The following is a description of a gene set: Mouse Gene Set: TABULA_MURIS_SENIS_MESENTERIC_ADIPOSE_TISSUE_MESENCHYMAL_STEM_CELL_OF_ADIPOSE_AGEING studied in species Mus musculus from publication Tabula Muris Consortium (PMID 32669714), and this is the list of marker genes: Sf3b2, Tppp3, Camk2n1, Gnb1, Tpt1, Elovl1, Ier3, Prr13, Rap1a, Ifngr2, Numbl, Eya2, Nras, H2-K1, Shisa5, Nbl1, Snai1, Laptm4a, Eln, Tmed9, Comt, Tex261, Pcnp, Ckb, Rab11b, Xbp1, Mtarc2, Dnaja1, Bclaf1, Cd151, Brd2, Pdxk, Arid1a, Fubp3, Fosl2, Anxa3, Rps7, Rpl8, Tmsb10, Cited2, Hsp90aa1, Ube2m, Serbp1, Rps20, Snrpb, Vat1, Sdf2l1, Btg1, Vapb, Ctbp2, Ccl11, Igsf3, Cytl1, Ccnl1, Ccnd3, Pdlim1, Mtdh, Elof1, Ints6, Iqgap1, Atn1, Hnrnpr, Rras, Rps9, Ddx39b, Rsrc2, Vapa, H2-D1, Rbpms, Lrp1, Tnfrsf1a, H2-Eb1, Sbds, Mdh1, Vps72 (vacuolar protein sorting 72), Gnas, Bcl3, Rpl13a, Abhd8, Dnajb1, Capg, Ier2, Trip10, Mospd3, Bcl7c, Arglu1, Ptms, Ptges3, Hsp90ab1, Map7d1, Prnp, Sox4, Emd, Zfp503, Ppp4c, Arpc4, Arpc2, Eva1b, Sox9, Fxyd6, Zfp36, Kmt2b, Apbb1ip, Mboat7, Pim3, Pabpc1, Czib, Cavin1, Ap2s1, E2f4, H2-M3, Rpl5, Zfand5, Eif1a, Tbcb, Rhoa, Rpl11, Mknk2, Hdac7, Eif1, Nkx2-3, Rspo1, Ybx3, Ddx6, Nav1, Pdlim4, Ralbp1, Tkt, Phb2, Eif3h, Npc2, Palld, Ebf1, Mtch1, Rpl17, Bmyc, Rnf126, Gm3336, Stxbp6, Hspa4, Spr, Ubxn1, Emc10, C3, Twf1, Abhd17a, Syf2, Eif4g1, Snrnp70, Sf3b4 (splicing factor 3b, subunit 4), Dbn1, Scn1b, Selenom, Marcks, Bin1 (NCBI Gene Id 30948), Thbd, Tomm6, Ppp1r11, Cebpg, Rps25, Zfhx3, Phactr2, Vcf1, Pa2g4, Eif4a1, Pfn1, Gatad1, Grb2 (growth factor receptor bound protein 2), Nfkbib, Dgat1, Eif4e, Tmem9, BC005624, Srsf9, Mea1, Zfpl1, Zfp703, Ddah2, Ftl1, Pla1a, Fkbp2, Clic4, Mgst1, Nucks1 (nuclear casein kinase and cyclin-dependent kinase substrate 1), Ift27, Rps2 (ribosomal protein S2), Bsg, Dock1 (NCBI Gene Id 71571), Csrp1, Tpm3, Ldha, Ifitm2, Hprt1, Eif3k, Rpl18, Palm, Psme1, Tpm2, Srrm2, Tcf7l1, Tmt1a, Eif3m (eukaryotic translation initiation factor 3, subunit M), Pkig, Slc25a3, C1qc, Arpc1b, Stx4a, Gadd45gip1, Trabd2b, Use1 (NCBI Gene Id 76848), Cotl1, Apoe, Aldoa, G3bp1, Fkbp8, Pcbp1 (poly(rC) binding protein 1), Kdelr1, Med1, Dnajc3, Mfap2, Babam1, Vamp2, Szrd1, Ak2, Hmox2, Zyx, Hmbs, Klf7, Hnrnpd, Has1, Igfbp7, Sumo3, Ltbp1, Znhit1, Ptp4a2, Cnp, Il3ra, Ube2e1, Ube2e3, Tmod2, Klf3, Plpp3, Pakap, Ptgis, Gsta3, Vezf1, Ifi211, Rrp1, Rarg, Eri3, Oaz1, Anp32b, Csrnp1, Tubb6, Prdx5, Nabp2, Srsf7, Arc (activity regulated cytoskeletal-associated protein), Tamalin, Cnpy3 (canopy FGF signaling regulator 3), Cxxc5 (NCBI Gene Id 67393), Rps3, Junb, Yme1l1, Rrbp1, Ccdc6, Arl6ip1, Rhoj, Hspa1a, Akt1s1, Rack1, Rock1, Actr2, Atoh8, Otub1, Pea15a, Ifi35, Set, Des, Rpl9, Tmem263, Snrpa, Ube2v1, Ubb-ps, Rhoc, Plin2, Lrrn4cl, Cltb, Hic1, Map2k2, Fgf18, Tsen34, Ino80e, Aig1, Rps5, Psmb8, 1700019D03Rik, Gna11 (NCBI Gene Id 327779), Stx5a, Tob1, Pebp1, Eef1b2, Rpl13, Steap3, Lmo4, Lsm2, Mapk3, Nsg1, Ramp2, Clec3b, Trappc3, Pdpn, Ubl7, Maf, Sdc4, Oaf, Myc, Bst2, Fam120a, Cd9, Fxyd1 (NCBI Gene Id 80524), Cmtm3, Golt1b, Tubb5, Inpp4a, Pnrc1, Spin1, Yif1b, Txn2, Tnfaip2, Cirbp, Gabarapl2, Eif5a, Cald1, Efhd2, Sod1, Mycbp2, Phf1, Fam89b, Mlf2, Trp53, Nudc, Rhob, Hspb1, Tmem160, Tmem250, Brd4, Ngf, Gstm1, Cfl1, H2-Ab1, Mn1, Cdkn1a, Creld2, Nr3c1, Ehd1, Calr, Ssbp3, Mmp11, Dhrs4, Rap2a, Arl2bp, Lmo2, Kdm6b, Ubxn4 (UBX domain protein 4), Ldhb, Nudt3, Plekhj1, Lmna, Ttyh2, Efcab14, Sfrp1, Ubtf, Mafb, Loxl1, Lamtor1, Zbtb7a, Spon2, Cebpb, Canx, Gabarapl1, Tomm22, Rps3a1, Kazald1, Rab5c, Aebp1, Hmox1, Plvap, Rheb, Scamp3, Marf1, Lrrc8a, Ggt5, Emc4, Map1lc3a, Ccdc124, Aldh2, Psmd4, Tob2, Ybx1, Arhgdia, Tomm40, Ces1d, G3bp2, B2m, Btbd2, Nsd3, Tgfb1i1, Wt1, B3gat3, Samd4b, Calm1, Il17d, Tmeff2 (NCBI Gene Id 77664), Rpl6, Basp1, Nufip2, Tspan3, Kif2a, Osr1, Gpx3, Itm2c, Lasp1, Calm3, Hdgf, Tacc1, Cygb, Inafm2, Cbx1, Ubb, Tmem150a, Mllt6, Qsox1, Tuba4a, Selenok, Cdkn1c, Polr2a, Raly, Rbms1, Sfrp2, Sigmar1, Lgmn, Mrfap1, C4b, Irf2bpl, Gapdh, Tagln2, Micu3, Creb5 (NCBI Gene Id 320189), Nfic, Mustn1, Impact, Crip2, Rps6, Ptpn1, Spry2, Lysmd2, Dapk1, Rbm42, Sumo1, Tle5, Furin, Puf60 (NCBI Gene Id 72802), Commd10, Tsc22d1, H3f3b, Rbm3, Map3k20, Adamtsl3, Map1a, Chd4, Wbp11, Snrpc, Nt5c3b, Manf, Gadd45b, Arl4d, Fus, Senp6, Gpx4, Plec (NCBI Gene Id 381012), Sh3gl1, Rab21, Cd36, Gnaq, Meg3, Aldh1a2, Dpt, Ptges, Rpl3, Ywhae, Tns1, Skil, Rplp0, Dhrs3, Ddhd2, Ece1, Jund, Ptov1, Btf3, Dlgap4, Kpna4, Eif3f, Cd63, Hnrnpa0, Ltbr, Mrtfb, Mcfd2, Adh5, Oaz2, Stbd1, Cavin2, S100a16, Zscan26, Pdlim7, Atf4, Bcl9l, Akr1c18, Fst, Bag3, Rtn3, Efemp1, Naca (nascent polypeptide-associated complex alpha polypeptide), Anapc11, Mxra7, Eef1d, Hes1, Cryab, Csnk2b, Akap13, Smim14, Cd248, Grina, Psmb4, Wbp2, BC005537, Nfia, Xist, Atp5f1d, Dcakd, Tcf7l2, Trf, Sdhc, Col8a1, Efna5, Tra2a, Nudt9 (NCBI Gene Id 74167), Rpsa (NCBI Gene Id 18445), Phlda3, Dpep1, Nr4a1, Sult5a1, Letm2, Rbm26, Chsy1, B4galt1, Cdk4, Fez1, Foxp1, Cdc37, U2af1, Mmp14, Arf6, Bptf, Acp1, Ptma, Rexo2, Arpc3 (actin related protein 2/3 complex, subunit 3), Srsf5, Ncoa3, Cdk2ap2, Pkm, Rps10, Arl8a, Eef1a1, Cystm1, Bri3, Atg101, Smarcb1, Mylip, Arf5, Gnai2, Map1b, Trappc6b, Ube2s, Arl6ip5, Vim, Usp2, Ssr1, Srm (spermidine synthase), Mapk1ip1l, Rpl7a, Fam219b, Mbd3, Acsl4, Pabpn1, Jak1, Drap1, Eif4h, Rnf10, Srsf2, Rpl27a, Adrm1, Nr4a2, Ccdc85b, Cnnm4, 4921531C22Rik, Tnfsf12, Klf9, Cxcl1, Gsk3b, Pltp, Cx3cr1, Prkaca, Cyba, Klf13, Rpl18a, Dvl3, Igsf8, Dbnl, Dda1, Cdv3, Enpp2, Gde1, Csnk2a1, Dpysl2, Rps24, Klf2, Polr3gl, Tax1bp3, Manbal, Selenow (NCBI Gene Id 20364), Tle3, Rbm25, Psip1, Ccl2, Prelid1, Ptgs1, Ssbp4, Capzb, Arl3, 4933434E20Rik, H2ax, Ep400, Lamtor4, Hras, Slc16a2, Arf1, Clic1, Sod3, Dtx3, Swi5, Litaf, Bad, Hebp1, Brd3, Gas7, Rpl4, Dusp3, Ewsr1, Keap1, Pold4, Alad, Ap1s1